The following is a description of a gene set: species: Mus musculus Genes down-regulated in MEF cells (embryonic fibroblasts) by overexpression of HOXC8. Mouse Gene Set: LEI_HOXC8_TARGETS_DN from publication Lei H, Wang H, Juan AH, Ruddle FH (PMID 15699330) Hox genes encode transcription factors that control spatial patterning during embryogenesis. To date, downstream targets of Hox genes have proven difficult to identify. Here, we describe studies designed to identify target genes under the control of the murine transcription factor Hoxc8. We used a mouse 16,463 gene oligonucleotide microarray to identify mRNAs whose expression was altered by the overexpression of Hoxc8 in C57BL/6J mouse embryo fibroblasts (MEF) in cell culture (in vitro). We identified a total of genes whose expression was changed by 2-fold or greater: genes were up-regulated, and genes were down-regulated. The majority of genes encoded proteins involved in critical biological processes, such as cell adhesion, migration, metabolism, apoptosis, and tumorigenesis. Two genes showed high levels of regulation: (i) secreted phosphoprotein 1 (Spp1), also known as osteopontin (OPN), was down-regulated 4.8-fold, and (ii) frizzled homolog 2 (Drosophila) (Fzd2) was up-regulated 4.4-fold. Chromatin immunoprecipitation (ChIP) analysis confirmed the direct interaction between the OPN promoter and Hoxc8 protein in vivo, supporting the view that OPN is a direct transcriptional target of Hoxc8., and this is the list of marker genes: Fam43a, Adam19 (ADAM metallopeptidase domain 19), Krt19, Serpinf1, Ankrd1, Grem2, Spp1, Elmo1, Gas1, Ass1, Cxcl10, Nqo1, Cnn1, Tagln (transgelin), Ncam1, Acta2, Plagl1